The following is a description of a gene set: Cell ion homeostasis / chemokines. species: Homo sapiens Human Gene Set: MODULE_262, and this is the list of marker genes: TFRC, CCL13, CCL11, HFE, XCL1, CCL14, CCL3, CCL19, STC1, TF, CXCL12, CCL23, MYC, CCL2, MT2A, CP, LTF, CCL15, CCL7 (C-C motif chemokine ligand 7)